The following is a description of a gene set: Human Gene Set: GOBP_NEGATIVE_REGULATION_OF_NERVOUS_SYSTEM_DEVELOPMENT species: Homo sapiens Any process that stops, prevents, or reduces the frequency, rate or extent of nervous system development, the origin and formation of nervous tissue., and this is the list of marker genes: DLL3, SEMA6C, LDLR, DICER1, IL6, PPP3CA, DLX2, TRPC5, DCC, DIP2B, NF2, WNT3A, SOX11, SEMA5A, RTN4, MCF2, LHX2, CTNNB1, ULK1, TGFB1, ID2, ELAPOR2, BRINP1, F2 (NCBI Gene Id 14061), TLX2, SPART, ATOH1, FGF13, MAP2, NTRK3, ARHGAP4, RNF10, BCL11A, HES5, BMP7, RNF6, TSPO, CCL11, SEMA4F, ASCL2, EFNB3, CBLN1, IDH2, SYNGAP1, MYCN, TRAK2, DAAM2, DKK1, NTN1, WNT5A, KCTD11, SKI, RTN4R, PSEN1, DAB1, PROX1, NKX6-1, RUFY3, YWHAH, HES1, RAPGEF2, DRD3, WNT3, GDI1, BMPR1A, GATA2, TLR2, TRIM46, MIR181C, CLSTN3 (NCBI Gene Id 9746), PCM1, SIRT2, CTDSP1, PITX3, NOG, ABCC8, ULK2, MAG, SLIT1, NOTCH1, SORL1, SOX10, EPHA7, B2M, PTN, NF1, DNAJB11, CDKL3, REST, DLX1, TREM2, PAX6, CDH1, GPR37L1, FSTL4, GORASP1, CERS2, CTNNA1, MIR181B1, TNR, BTG2, MIR137, MIR146A, KIFAP3, DUSP10, TMEM98, DRAXIN, SPP1, RYK, NRP1 (neuropilin 1), ID4, TRPC6, SEMA6D, TP53, MT3, HDAC6, SEMA3G, TRIM11, NR2E1, NR1D1, IL1B, VSX2, LRP4, NKX6-2, PTPN13, IFRD1, PTPRS, VAX1, DPYSL5, DYNLT1, NFATC4, RGMA, APPL2, SYT4, HOOK3, LIN28A, CDK5, PRTG, ROBO2, EPHB2, PLXNA3, TNF, THY1, KIAA0319, WNT7A, PTEN, SEMA3F, HMGA2, RB1